Given this list of marker genes TCN2, RAB43, BCL2L11, UBE4B, WDHD1 (NCBI Gene Id 11169), LY6D, TMCC1, USP7, TYRO3, ENDOU, DYRK2, RNF157, OPA1, PRDM2, CHST15, APC2, STK10, FHIP2B, TACR2, AACS, UPF2, ALKBH5, STRA6, CCDC93, SHMT1, PPARD, UBA6, ESR1, FSHB, CADM1, CTNND2, BACH2, S1PR3, WASL, TBX15, TENT4B, NEK5, TBX6, SAPCD1, C1QBP, APCDD1, FAM120AOS, AKAP13, BIRC6, BMP2K, PIK3AP1, SLC38A1, LPAR2, AP3M2, ZGRF1, CISH, CHFR, BANK1, NDP, FAM174B, RBP7, RAD18, ABI2, AGO1, PKIG, PDS5B, MED13L, COL19A1, MYB, GRAMD2B, KCNJ5 (NCBI Gene Id 3762), SDC4, ATXN2, ATF7IP, ULK4, ITPR1, CPSF7, FAM78A, SEMA4D, PTGDR2, HOXD9, EPHA2, AFF3, PARP14 (poly(ADP-ribose) polymerase family member 14), MIDEAS, MED1, GBP6, KCTD5, POMGNT2, CAMK1D, FCN1, ZFX, LPAR1, KBTBD11, ANKLE2, ZNF397, CASS4, TBC1D16, PEAK1, SEMA4A, MTMR9, PIERCE1, AP2A2, RBP2, SRPK1, TRAF3IP2, DYNC2H1, TBL1XR1, CRACDL (NCBI Gene Id 343990), SH2D5, RASGRP3, TLE1 (TLE family member 1, transcriptional corepressor), ZEB1, PRKCB, KRT16, TTC13, VPREB1, SRRM2 (NCBI Gene Id 51462), RSPO4, NPHS1, HOXB13, FLCN, SLC38A2, ACBD4, ST8SIA1, PGR, HARS1, SLCO4A1, CNTD1, HELZ2, PLCG1, MAML1 (mastermind like transcriptional coactivator 1), C2orf88, DHX33, CHRNA2, SEC61A1, PARP1, UBP1, BLTP3A, CREBBP, PLEKHA7, PIP4K2A, SLC15A3, POLH, MYH1, RNF38, ZNF296, RAPGEFL1, SLFN13, HMGCS1, TIAM1, WNK1, ZNF329, PDE2A, PLEKHA2, ZC3HAV1, GPSM1, CLCN3 (NCBI Gene Id 133073), FAM120A, LGALS4, FOXN3, ABL2, USP34, RBM10, ADGRB2, STING1, FOXO1, FAM8A1, MEF2D, IL2RA, NOTCH1, TRIM25, USP42, DHX30, ITSN1, KIAA0930, GRAP, TNRC6A, MLH1, CD36, HGH1, ASXL1, GAL3ST1, ABHD2, SLC7A1, HSPH1, SCCPDH, CD79A, TXNIP, MGST2, RASSF9, IL7R, ANKRD45, XPO7, ZFP36L1, TMEM109, PRKCA, ATP7A, HSD17B7, SNHG7, BLNK, TNFRSF17, LGI3, CDIPT, TP53INP1, here is a description of the gene set: Human Gene Set: GSE5503_MLN_DC_VS_PLN_DC_ACTIVATED_ALLOGENIC_TCELL_DN from publication Kim TD, Terwey TH, Zakrzewski JL, Suh D, Kochman AA, Chen ME, King CG, Borsotti C, Grubin J, Smith OM, Heller G, Liu C, Murphy GF, Alpdogan O, van den Brink MR (PMID 18178870) Genes down-regulated in allogeneic T cells after stimulation with dendritic cells from lymph nodes: mesenteric (mLN) versus peripheral (pLN). Transcriptional response of murine allogeneic T cells (B10.BR) after stimulation with different organ-derived (spleen, liver, peripheral and mesenteric lymph nodes) dendritic cells (C57BL/6) in vitro studied in species Homo sapiens